The following is a description of a gene set: part of: Downstream signaling of activated FGFR1 The ability of growth factors to protect from apoptosis is primarily due to the activation of the AKT survival pathway. P-I-3-kinase dependent activation of PDK leads to the activation of AKT which in turn affects the activity or expression of pro-apoptotic factors, which contribute to protection from apoptosis. AKT activation also blocks the activity of GSK-3b which could lead to additional antiapoptotic signals. Reactome Pathway: PI-3K cascade:FGFR1 species: Homo sapiens, and this is the list of marker genes: PIK3R1, FGF2, FGF9, FGF23, FRS2, GRB2, FGF20, PTPN11, PIK3CA, FGFR1, FGF4, FGF17, FGF3, FGF10, GAB1, FGF1, FGF8, FGF6, FGF5, FGF22, KL